The following is a description of a gene set: studied in species Mus musculus Mouse Gene Set: MIR_669M_3P from publication Chen Y, Wang X (PMID 31504780) Genes predicted to be targets of miRBase v22 microRNA mmu_miR_669m_3p in miRDB v6.0 with MirTarget v4 prediction scores > 80 (high confidence targets)., and this is the list of marker genes: Kmt2c, Calca, Dgkd, Casp8ap2, Lrp8, Tm9sf3, Tle1, Strbp, Fgd4, Mospd1, Vcan, Klf6, Krt73, Heatr5b, Kbtbd7, Ttc7, Txlng, Smo, Ppat, Tnfaip8, Dennd4a, Lamtor3, Gch1, Dleu7, Yy1, Ddx10, Cav2, Kif21a, Rab14, Ube2b, Ppa2, Evx1, Srpk2, Rif1, Rsbn1, Cxcl5, Schip1, Lats1, Jph1, Olfml2b, Tgfbr3, AI182371, Tob2, Gm5114 (predicted gene 5114), Aak1, Erf, Ifit2, Rap1gap2, Tmem41b, Fli1, Prickle1, Lix1l, Avl9, Mfsd1, Mast4, Rb1cc1, Marf1, Neto1, Fam210a, Hoxd1, Tmem151a, Efnb2, Uty, Eif4enif1, Arhgef10l, Ank2, Diaph2, Rnf4, Fbxl17, Map2, Pum2, Cdh9, Cd209a, Ccser1, Rnf144a, Calu, Ssb, Pms1, Ccdc25, Srgap3, Itga2, Cwc22, Hopx, Nlrp2, Glo1, Qrfprl, Irs1, Sh3gl3, Btaf1, Marchf6, U2surp, Ube3c, Kif3a, Asah1 (NCBI Gene Id 67617), Zfp608, Bmp5, Fgl2, Calcr, Tfg, Fbxl5, Serpinb10, Ano4, Homer1, Gria3, Zic1, Vps35, Ugt2a1, Lrp1b, Il7, Timp3 (NCBI Gene Id 268324), Fbxo33, Pira2, Svil, Sdcbp, Sh3gl2, Lpl, Ulk2, Emc7 (NCBI Gene Id 98979), Unk, Akap6, Eif4ebp1, Cacng5, Sema3a, Ctsc, Pea15a, Phrf1, Med13, Golph3, Lztfl1, Cxcl16, Cul3, Pgm2l1, Pitx2, A630023A22Rik, Tnrc6c, Pmp22, Six6, Zfp850, Sema4b, Gopc, Rad51d, Ankrd13c, Tle4, Sdad1, Pcf11 (NCBI Gene Id 97363), Zranb3, Ndnf, Nefl, Hip1, Pira12, Zfp704, Usp42, Tab2, Edil3, Dip2b, Gucy1a2, Tshz3, 1110059G10Rik, Cstf3, Tagap1, Kif2a, Sav1, Tasp1, Ets1, Cks2, Zfp935, Wtap, Zbtb10, Ino80, Clcn2, Taok1, Kcna2, Dusp10, Eml6, Plxna2, Tagap, Sbf2, Cep135, Rasef, Cebpg, Zdhhc21, Yaf2, Mthfd1, Myadm, Topbp1, Erg28, Pafah1b1, Dcun1d4, Eea1, Mphosph10, Rab10, Rgs17, Trim34a, Mllt10, Zfp592, Arhgef7, G2e3, Kmt2e, Itch, Mex3c, Btbd3, Zmat1, Cnbp, Akap9 (A kinase anchor protein 9), Kank1, Itgb1, Nkrf, Asxl1, Slc18a2, Lrrc7, Fgfr2, Epha7, Zfyve16, Arid1b, Sox21, Zrsr2, Rbm27, Zfp148, Ckap2 (cytoskeleton associated protein 2), Ppfia2, Nectin3, Nrbf2, Pcdh7, Secisbp2l, St8sia4 (NCBI Gene Id 20452), Arhgef11, Zbtb44, Ssbp2 (single-stranded DNA binding protein 2), Araf, Rsf1, Rgs4, Cfap20, Sft2d3, Fut9, Skint9, Usp6nl, Iqschfp (Iqcj and Schip1 fusion protein), Otx2, Tmtc2, Mrpl39, Loxl3 (NCBI Gene Id 16950), Ythdc2, Gtf2b, Vps13d, Appl1, Tceanc, Slc38a2, Rai1, Elovl5, Zfp36l2, Alcam, Dmrta2, Nrf1, Zfp30, Tubgcp5, Phf8 (PHD finger protein 8), Adamts1, Prpf4b, Arhgef33, Fhip1b, Chrna1, Adgrf5, Zbtb11, Crybg3, Dcdc2a, Camk2d, Gm15881 (predicted gene 15881), Sptbn1, 1700066M21Rik, Prr12, Hhip (Hedgehog-interacting protein), Ppm1h, Fbxo34, Egln1, Tnfrsf11b, Zfp182, Usp25, Pik3c2a, Zmym6, Ccar1, Btg1, Spag9, Trpc1, Akap13 (NCBI Gene Id 76109), Camsap2, Sfpq, Grpr, Arfgef2, Osbpl8, Tbx22, Mkrn2os, Dennd2b, L1cam, Ctla4, Rbbp5, Hectd2, Gfod1, Msx2, Zbtb2, Cramp1, Mcu, Fosb, Cflar, Tada2b, Herc1, Ddx21, Gabra1, Dlat, Phf6, Rnf214, Slc17a6, Zfp521, Dph6, Rock2, Grsf1, Adamts17, Nr1i2, Bmp3, B3galt2, Pfkfb3, Ubqln2, Glipr1l2, Nom1, Nr3c2, Akain1, Ubxn7, Rev3l, Gm5592, Gk, Rnf111, Pdik1l, Gpatch8, Cilk1, Zswim6, Mbnl2, Set, Il1rap, Klhl14, Dck, Mapk1, Epha4, Eif1ad, Gabra2, Rictor, Evx2, Cttnbp2, Rad21, Alg6, Milr1, Ccnc, Hook3, Slc4a7, Lrrc42, Herc6, Zbtb41, Rbm25, Zwint, Mef2d, Gm4884, Far1, Enpp1, Clec12a (C-type lectin domain family 12, member a, NCBI Gene Id 232413), Dbx1, Apobec3, Mpzl1, Slc8a1, Ptp4a3, Fam76b, Ptprd, Ankhd1, Carmil1 (capping protein regulator and myosin 1 linker 1), Cntfr, Tspan12, Extl2, Dync1li2, Eif5a2, Elmod1, Adam23, Adgre4, Epc2, Syt13 (NCBI Gene Id 99017), Septin9, Spty2d1 (SPT2 chromatin protein domain containing 1), Nectin4, Hdac4, Ptprr, Lemd3, Fzd8 (frizzled class receptor 8), B3galt1, Usp32, Znrf3, Ralgds, Hivep1, Tjp2, Tmc8, Marchf7, Plekhm3, Syncrip, Necap1, Vkorc1l1, Mbd4, Dock11, Mtmr6, Vps13a, Xpo7, Col19a1, Tardbp (NCBI Gene Id 97174), Rcn2, Arhgap29, Gucy1b1, Trim68, Rbfox1, Zfp811, Spred1, Arl8a, Kcne4, Zc3h12c, Foxa1, Prr16, Bmper, Myrf, Nxt2, Naa20, Stk24, Spin1, Csmd2, Casz1 (NCBI Gene Id 69743), Ndst3, Tmem68, Etv3, Nup35, Hycc2, Tmem215, Stard13, Grm5, Map7d2, Psd3 (NCBI Gene Id 80295), Med14, Rgmb, Crebrf, Otud4, Anks1b, Epb41l1, Serpinb9g, Dnali1, Zfp280d, Bmpr2, Hmgxb4, Kdm6a, Nr4a3, Kif13a, Fech, Arl6ip6, Atad1, Arap2, Rngtt, Lin9, Zfp1008, Styx, Arid4b, Sh3rf1, Tbc1d22b, Chek2, Zfp451, Runx2, Rerg, Tmem196, Myo9a, Lrp6, Ttll7, Bdnf, Gpm6b, Prkcd, Myt1l, Abcb1b, Rab7, Mrc1, Khdc4, Mex3b, Ccdc120, Ankrd1, Trhde, Kcnma1, Dlg2, Rasa2, Gata3, Rab11fip3, Gm3604, Foxf2, Ccdc68, Lifr, Fchsd2 (NCBI Gene Id 97424), Ugt2a2, Rab11fip2, Lhx8, Impg2, Itpr1, Wdfy3, Nfyb, Spry1, Ctdspl2, Nek1, Sim1, Xiap, Trhr, Scn2a, Cacna1b, Rab11b, Tcerg1l, Dnttip2, Ino80d, Ptprb, Plag1 (NCBI Gene Id 56711), Wdr43, Wrap73, Gpcpd1, Bdp1, Fgf4, Ntrk2, Golim4, Pde4dip, Csgalnact2, Spock3, Satb2, Rtn1, Pip4p2, Tob1, Cask, Pcsk5, Lin52, Rnf38, Cmtm8, Zfp407